Given this list of marker genes RBP7, AP2B1, RNF41, SWSAP1, TCF7, KRAS, RPGRIP1, KLK1, DUSP22 (NCBI Gene Id 56940), ZIC3, TMEM222, FTH1, SLC35A3, VAPB, ETFRF1, ACOX1, BID, NCF2, LEP, KDM8 (lysine demethylase 8), EIF3A, SIGMAR1, MSRA, FGFR2, GOSR2, MFAP5, SPAG5, IL6ST, PTTG1, PITX2, SLC25A30, HACD3, NPM3, PSME4, HSPA9, CXCL12, HSD17B11, TCF12, MR1, PPP3CA, WASHC2C, GIT2, SERINC3, DCUN1D1, QSOX1, CD59, MNDA, EGFR, SOD3, SLURP1, NEU2 (NCBI Gene Id 4759), DNM2, ITGA9, CFL2, UCK1, TPP2, FNTA, EIF4H, ASPH, CCND2, IL36G, ARL5A, CAT, PTGFR (NCBI Gene Id 5737), PNPLA2, PRELP, PRKAR1B, NCOA4, NSMAF, PTPRZ1, SULT2B1, HOXB2, IP6K1, RBMS1, BNIP3, CDC42BPA, ITIH5, CLNS1A, KRT12, ART1, PRKACB, UQCRB, SPPL2B, NR3C1, MRAP, CENPB (NCBI Gene Id 92501), DPYSL3, AP3M1, NABP1, IMMT, SLC11A2, ZNF260, FBLN1, HCFC1, CYSRT1, QPCT, ARPP19, TSPAN3, ALOX5AP, PCSK6, MIR214, PINK1, TGFBR3, SPTBN1, IDH3G (NCBI Gene Id 3421), SMOC2, ATP2A2, ACTRT2, CENPV, LANCL1, CYP4B1, CCN3, AHR, KLHL13, ELOC, NUBP1, SLC22A5, LGALS3BP, RAB31, ACYP1, ADH1A, RRM1, SGPL1, IL1R2, SLC39A3, HBP1, TXNDC12, KIF11, TCAP, TRIAP1, SLC25A10, FAM107B, S100B, AMD1, USF1, TUBGCP2, ATPAF2, UBE2H, H1-2, PTPRF, TM6SF1, WDR48, MEF2A, MORC3, SOX4, MSR1, ENPP3, CHPT1, DRAM1, PRKD3, NEDD4, LAPTM4A, TCIM, PRDX1, DRAM2, CACNA2D1, NIT2 (NCBI Gene Id 56954), TREX2, SRGN, SLC48A1, UBAP2L, TBK1, FAM162A, CMTR1, NAP1L1, GSTA2 (glutathione S-transferase alpha 2), DUSP1, ZFR, ADIPOQ, CAPZB, CTBS, SPON2, CCL15, ATXN7L3B, TYROBP, TMEM191C, ASB7, BAD, CD163, SERPINA12 (NCBI Gene Id 145264), RABGAP1, TSPO, ADD3, NSUN4, THBS1, TFPI2, ILF3 (NCBI Gene Id 54783), IL2RG, CALCOCO2, RGS4, IFI16, ASB6, PITPNB (phosphatidylinositol transfer protein beta), NNAT, HIPK3, SELENOF, TPSB2 (tryptase beta 2), EIF4G1, TIMP1, SORBS1, ACAA2, ARCN1 (NCBI Gene Id 372), MOB1A, HAS3, PDGFA, VIRMA, C4orf3, FUCA1, FECH, RXRA, ACO1, RXYLT1, ACSL1, LXN, CLCA3P, QKI, GINM1, SH3KBP1, TXNIP, LCE1B, PLD1, ETFDH, UCP3, LRRC8C (leucine rich repeat containing 8 VRAC subunit C), ART3, BMP1, RPA1, ARRDC4, BPHL, RAB40C, NDUFS4, S100A10, SCD, B2M, TMEM234, RNF114, THRSP, ARHGAP1, HBS1L, PEA15, SIX2, COA5, AIF1L, CAPRIN1, SCUBE1, UCP1, HOXA9, GET3, CLDN10, TPSD1, CYP11A1, CPA3, CDH5, BBOX1, FERMT3, TF, ATF2, IFT46, NDRG1, GSK3B, GNAS, SEPTIN8, ACKR1 (atypical chemokine receptor 1 (Duffy blood group)), CFAP97, EPS8L1, SRPK1, XDH, ZNF106, OPA1, BRAT1, CSRP3, SNRPN, PLGRKT, HSPB7, WARS1 (tryptophanyl-tRNA synthetase 1), CELF2, SLC25A13, HLA-DQA2, NLK (nemo like kinase), INTS12, BAG4 (BAG cochaperone 4), EML5, KLB, PRMT6, PLAC1, KRTDAP, FOS, TGFBI, EPHX2, IGF2, ZDHHC5, TP63, HDLBP, LGALS1, FHL2, PTPRG, LBP, IKZF1, ERI2, HLA-B, CHRND, PCCA, BCL2L13, MYL1, SIRPA, ACTB, TCEA1, MS4A6A, SORT1, SKP2, ESD, PBK, PC, CHST1, SCOC, RARRES2, GNA13, SERPINB4, CHCHD10, AGTR2, GSTZ1, SMAD5, UAP1 (UDP-N-acetylglucosamine pyrophosphorylase 1), GNA12, PRPS1, ABCC5, KLF3, PON3, EPAS1, PIP4K2A, TM6SF2, FADS2, COL4A5, RAMP2, TNFAIP6, TMCC2, SERPINF1, HDC, SGCG, PDPK1, TWSG1, BICD2, LYZ, GPSM1, TP53INP2, STOM, CLDN11, PILRA, ZNF521, ITM2A, MTX1, CA3, ZC3H11A, PTBP3, PEX13, SLC25A48, PSAP, AK3, CTSB, ATP2A1, TRIB1, AVPR1A, CTTN, LPL, RECQL, CA4 (NCBI Gene Id 762), ME1, SLC6A4, FBXW8, IGHG1, CNOT4, BZW1, CP, MYL4, SEC61A2 (NCBI Gene Id 88207), TMEM106C, GZMH, CASP6, PFKFB3, DDX3Y, SPRR1B, RPTN, PIP5K1A, ABCB8, LGALS9, LMBR1, RBBP4 (NCBI Gene Id 91125), BABAM2, CCN1, IER3, S100A8 (NCBI Gene Id 6279), TSLP, CAB39L, MRC2, PTGS2, RETN, LANCL2, SNX17, SLC22A2, FGFBP1, EREG, CDKN1A, FGL2, RNF14, LIMS1 (NCBI Gene Id 3987), GZMB, IMMP2L, LUM, PSMF1, VN1R17P, RTN4, TUBA4A, CD44, SNRNP27 (small nuclear ribonucleoprotein U4/U6.U5 subunit 27), LASP1, LPIN1, SLC4A10, MARCHF2, DNAJB1, ESYT3, ST3GAL2, PUM1, CAMK4, PARP3, IL18R1, ACAD8, ZNF445, MYO5B, ANGPTL2, ZFP37, ALDH1A1, AP2A1, PCYT1A, LILRB1, LCP1, ACBD3, KRT77, DHX40, HADH, ZBED3, IL36A, PRR13, MST1R, MAPRE2, STARD4, FSCN1, HNRNPLL, PKDREJ, AGPAT5 (1-acylglycerol-3-phosphate O-acyltransferase 5), SERPINB1, SERPINB9, CTR9, LIPA, CTF1, ACTN3, RIMOC1, ALAS1, NCF1, CER1, MCM6, HCAR2, NDST2, PCK1, SNCG, SUCO, SPRR2D, FCGR2B (NCBI Gene Id 2213), IL33, HAVCR2, MAP1B, CAPN6, CASQ1, LMNB1, SLC1A5, FBP2, AKR1B10, ATF3, NSF, GRB10, KRT6B, CPT1B, LTC4S, EGLN3, CSF1R, SERPINB2, SPIN1, SERP1, CEP85, INPPL1, NR4A1, ADD1, LY6D, KRT16, TFRC, TGFBR2, C1QB, PLIN4, CAV2, NADK, ACTA1, C5orf15, SDCBP2, RAD21, LIPE, CPD, CA13, CMA1, SLC26A7, LRG1, CKM, TNFSF14, DAP, PECAM1, CHEK2, LITAF, CTDSP2, FAH, POU2F3, APOA4, HOXB6, RANBP9 (NCBI Gene Id 10048), LMAN1, CLCF1, PRKCE, DVL1, EMP2, TMEM45A (NCBI Gene Id 55076), PDLIM5, UBE2D3, SREK1IP1, OS9, STAR, UBB, TBRG4, C1orf54, GHR, CFD, XRN2, GLO1, HMGCS2, SLC2A4, GBP2, RACGAP1, MAP2, PDK4, FUT2, DNPEP, TMEM109, TMED9, BCAP31, CD36, RAB2B, DCTN4, USHBP1, AQP1, PLA2G2F, PIGO (phosphatidylinositol glycan anchor biosynthesis class O), CAV3, KIF20A, CCNL2, APOC2, ZNF410, CLDN5, NUDT7, CIDEC, IL36RN, JAK1, RGCC, SAR1A, CARS1, PMEPA1, ITGAV, OSR2, GJA1, MRPL3, CEACAM1, USP34, SLC14A1, NPY4R, DGCR2, FABP4, WDR45, COX6A1, RFC1, BTC, HMGA2, TGFB2, PAPOLA, PDGFC, TP53, NT5E, ARL8B, ITGA4, GPD1, PLEK2, TSHR, HIF3A, CLDN15, FABP1, TMEM106B, DTX3, LDHC, PTPN14, RSAD2, HNF4G, MAN1A2 (NCBI Gene Id 10905), UTY (NCBI Gene Id 7404), CHD9, DDX3X, CLEC4E, ROPN1L, IDE, CCL20, CD74 (NCBI Gene Id 972), GLRX, AGK, YKT6, TRBC2, IFI27L2, ZNF330, WEE1 (WEE1 G2 checkpoint kinase), here is a description of the gene set: from publication Martínez-Cruz AB, Santos M, Lara MF, Segrelles C, Ruiz S, Moral M, Lorz C, García-Escudero R, Paramio JM (PMID 18245467) Squamous cell carcinomas (SCC) represent the most aggressive type of nonmelanoma skin cancer. Although little is known about the causal alterations of SCCs, in organ-transplanted patients the E7 and E6 oncogenes of human papillomavirus, targeting the p53- and pRb-dependent pathways, have been widely involved. Here, we report the functional consequences of the simultaneous elimination of Trp53 and retinoblastoma (Rb) genes in epidermis using Cre-loxP system. Loss of p53, but not pRb, produces spontaneous tumor development, indicating that p53 is the predominant tumor suppressor acting in mouse epidermis. Although the simultaneous inactivation of pRb and p53 does not aggravate the phenotype observed in Rb-deficient epidermis in terms of proliferation and/or differentiation, spontaneous SCC development is severely accelerated in doubly deficient mice. The tumors are aggressive and undifferentiated and display a hair follicle origin. Detailed analysis indicates that the acceleration is mediated by premature activation of the epidermal growth factor receptor/Akt pathway, resulting in increased proliferation in normal and dysplastic hair follicles and augmented tumor angiogenesis. The molecular characteristics of this model provide valuable tools to understand epidermal tumor formation and may ultimately contribute to the development of therapies for the treatment of aggressive squamous cancer. Human Gene Set: MARTINEZ_RB1_AND_TP53_TARGETS_UP Genes up-regulated in mice with skin specific double knockout of both RB1 and TP53 by Cre-lox. studied in species Mus musculus